Given this list of marker genes SEPTIN7, CENPJ, WRAP73, SEPTIN9, ATMIN, MAK, MAP4, BBS4, HAP1, TTBK2, CEP135, RP1, here is a description of the gene set: studied in species Homo sapiens Any process that modulates the frequency, rate or extent of non-motile cilium assembly. Human Gene Set: GOBP_REGULATION_OF_NON_MOTILE_CILIUM_ASSEMBLY